The following is a description of a gene set: Human Gene Set: MORF_XRCC5 Neighborhood of XRCC5 X-ray repair complementing defective repair in Chinese hamster cells 5 (double-strand-break rejoining; Ku autoantigen, 80kDa) in the MORF expression compendium Neighborhood of XRCC5 species: Homo sapiens, and this is the list of marker genes: EIF3M (NCBI Gene Id 63319), SRSF9, ADD1, SDHB, GNB1, NCL, TRRAP, SLBP, PABPN1, CS (NCBI Gene Id 94822), WDR18, IMPDH1, NSD2, HDAC1, BAG6 (BAG cochaperone 6), CALM2, HMGB1, TUBA3C, DNAJC11, ICE1, NUDT1, UBE2L3, PRKDC, MGRN1, NRDC, TIMM17A (translocase of inner mitochondrial membrane 17A), CSK, DDX39B, AP3D1, COQ9, H2AZ2, FUS (FUS RNA binding protein, NCBI Gene Id 406232), SRP14, HNRNPA2B1, RAD23A, PRPF40A, UPF3A, SMARCC1, VDAC2, TOMM70, ATXN10, KHDRBS1, IARS1, CDC16, TRA2B, PTDSS1, API5, MDH1, NDUFS2, SET, DAP3, SREBF2, UQCRH, PDHB, HNRNPD, NUDC, SNRPE, ESD, XRCC6, TXNL4A, VDAC3, G3BP2, PTPRA, SAFB, DEK, HNRNPAB, XPO1, FIBP, FH, MCM6, GANAB, LSM7, CTBP1, DIAPH1, SEPTIN7, USP1, DYNLL1, YWHAQ, ATP5PO, HAX1, NARS1, POM121, CBFB (core-binding factor subunit beta), RNF44, SLC25A3, SNRNP200, RPIA, HADH, DNAJC9, PHB2, PUM2, PDIA6, SLC35E2A, AATF, EIF1AX, TXLNA, NUP188, TMEM123, MAPRE1, SNRNP70, GNG5, ARPC3 (actin related protein 2/3 complex subunit 3), SRSF2, SMARCC2, UBE2D2, PABPC4, PPP1CC, TREX2, HNRNPU (heterogeneous nuclear ribonucleoprotein U), ARIH2, EIF3I, TRAPPC3, XRCC5, TCERG1, DNAJC8, FAM168B, NAE1, RUVBL2, SNRPA, SSB, RNPEP, ACP1, XPO7, PARK7, CAPZA1, MTREX, TUFM, NDUFS4, SSRP1, U2AF1, STK24, RO60, HDAC2, SRSF1, CCT7, PAPSS1, R3HDM1, CAMKK2, DNMT1, ZPR1, CLPP, LSM2, HNRNPR, PSMB7, RRM1, AKR7A2, SUMO2, DKC1, H2AZ1, TERF1, MLEC, PIN1, LYPLA1, CTDNEP1 (CTD nuclear envelope phosphatase 1), STMN1, PRPF8, EIF3D, POLR2A, HDDC2, PRPS2, ATP5MC1, HNRNPC, TIAL1, NSA2, NDUFS5, UBE2I, NDUFA7, ATP5MC3, DDX49, HNRNPM, CDK2, PPM1G, NONO, WDR1, ACLY, POLA2, PPIE, BRD8, PSMA1, RNPS1, BUB3, CAP1, BAZ1B, ANP32A, PTGES3, GPAA1 (glycosylphosphatidylinositol anchor attachment 1), TCP1, MCM2, IMMT, ANAPC5, KXD1, TOMM20, YARS1, SRRM1, AFG3L2, LRPPRC, PCMT1, EIF4EBP2, DOCK3, RPN1, GTF2A2, IFRD1, TYMS, COX5B, LBR, PRPF31, HNRNPUL1, CCT2, AHSA1, SSBP1, MPHOSPH9, HADHB, DCTD, HCFC1, IDH3B, NDUFV1, GPN1, DHX9, THOP1, STARD7, DDX19A, CHAF1A, PTBP1, DDX19B, DUT, TCEA1, TARDBP, JTB, EPRS1, MCFD2, EIF3H, NAP1L4, ILF2, ACTR2 (NCBI Gene Id 10097), TM9SF2 (transmembrane 9 superfamily member 2)